Given this list of marker genes POLR1D, POLR2L, POLR3GL, POLR2H, POLR3H, POLR2E, POLR3A, POLR3B, POLR2F, CRCP (NCBI Gene Id 27297), POLR3G, POLR3E, POLR3D, POLR3C, POLR1C, POLR2K, POLR3K, POLR3F, here is a description of the gene set: Human Gene Set: GOCC_RNA_POLYMERASE_III_COMPLEX RNA polymerase III, one of three nuclear DNA-directed RNA polymerases found in all eukaryotes, is a multisubunit complex; typically it produces 5S rRNA, tRNAs and some of the small nuclear RNAs. Two large subunits comprise the most conserved portion including the catalytic site and share similarity with other eukaryotic and bacterial multisubunit RNA polymerases. The remainder of the complex is composed of smaller subunits (generally ten or more), some of which are also found in RNA polymerase I and others of which are also found in RNA polymerases I and II. Although the core is competent to mediate ribonucleic acid synthesis, it requires additional factors to select the appropriate template. studied in species Homo sapiens